Given this list of marker genes Acaa1a, Cops3, Zbp1, Mllt6, Fkbp5, Ssbp4, Kbtbd11, Zfp1, Isg20, Bcl3, Lars2, Atp1b3 (NCBI Gene Id 11933), Il2rb, Syt11, Prkch, Ndrg3, Socs3, Frmd8, here is a description of the gene set: studied in species Mus musculus from publication Cui A, Huang T, Li S, Ma A, Pérez JL, Sander C, Keskin DB, Wu CJ, Fraenkel E, Hacohen N (PMID 38057668) Genes positively differentially expressed in cell type: Treg upon treatment with cytokine: OSM in mouse lymph nodes in vivo. Mouse Gene Set: CUI_TREG_OSM_RESPONSE_UP Cytokines mediate cell-cell communication in the immune system and represent important therapeutic targets. A myriad of studies have highlighted their central role in immune function, yet we lack a global view of the cellular responses of each immune cell type to each cytokine. To address this gap, the authors created the Immune Dictionary, a compendium of single-cell transcriptomic profiles of more than 17 immune cell types in response to each of 86 cytokines (>1,400 cytokine-cell type combinations) in mouse lymph nodes in vivo. A cytokine-centric view of the dictionary revealed that most cytokines induce highly cell-type-specific responses. For example, the inflammatory cytokine interleukin-1β induces distinct gene programmes in almost every cell type. A cell-type-centric view of the dictionary identified more than 66 cytokine-driven cellular polarization states across immune cell types, including previously uncharacterized states such as an interleukin-18-induced polyfunctional natural killer cell state.